Given this list of marker genes Zfp13, Hbb-bh2, Prdx3, Nnt, Cyp1a1, Hbb-bh0, Duox2, Hbq1b, Insr (NCBI Gene Id 319666), Epx, Txn1, Noxa1, Gpx3, Hbb-bs, Cybb (NCBI Gene Id 97621), Ncf1, Tpo, Hbq1a, Snca, Park7, Cat, Prdx4, Nox1 (NADPH oxidase 1), Prdx1, Cycs (NCBI Gene Id 13063), Hbb-bh1, Nox4 (NADPH oxidase 4), Cyba, Pxdn, Pink1, Stat3, Acox1, Mfn2, Duox1, Duoxa1, Hba-x, Hbb-bt, Ptger4, Cyct, Cyp1a2, Egfr, Abcc1, Fyn, Mt3, Prdx6b, Apoa4, Mpv17l, Sod2, Duoxa2, Mpo, Hbb-y, Ctns, Gpx1, Prdx6, Prdx2, Hba-a1, Txnrd1, Prdx5, Sod1, here is a description of the gene set: Mouse Gene Set: GOBP_HYDROGEN_PEROXIDE_METABOLIC_PROCESS studied in species Mus musculus The chemical reactions and pathways involving hydrogen peroxide (H2O2), a potentially harmful byproduct of aerobic cellular respiration which can cause damage to DNA.